The following is a description of a gene set: The change in morphology and behavior of a mature or immature B cell resulting from exposure to a mitogen, cytokine, chemokine, cellular ligand, or an antigen for which it is specific. Human Gene Set: GOBP_B_CELL_ACTIVATION species: Homo sapiens, and this is the list of marker genes: LIG4, IFNA6, MALT1, ITM2A, VAV3, WNT3A, RAG1, INPP5D, STAT5B, ZBTB7A, CDKN1A, LYN, PIK3R1, KMT5C, HMGB3, TGFB1, MIR185, MSH2, NFAM1, DOCK10, TLR4, AQP8, FOXP3, TCF3, NOTCH2, TRAF3IP2, SLC39A10, TNFRSF13B, CD22, IGHE, IFNA7, C3, FCRL1, PRLR, CD19, NSD2, TNFAIP3, IL11, TPD52, CCR6, KMT5B, ITGA4, IFNA21, SPI1, TLR9, POLM, SHLD1, MNDA, CHRNA4, PRKCB, IGHM, BLNK, IL10, IFNA16, LYL1, ITGB1, YY1, IRF2BP2, FOSL2, ABL1, TNFSF4, IFNA17, ADAM10, TYROBP, TBX21, CTLA4, CD81, THEMIS2, EP300, LGALS1, CD40, AHR, CYLD, PTPN2, NHEJ1, FLT3, PHB1, BTK, UNG, ADA (adenosine deaminase), IL9, EPHB2 (EPH receptor B2), IFNW1, NDFIP1, IFNA14, ADAM17, SFRP1, IL6, EXOSC3, SHB, SUPT6H, CASP8, RBPJ, ZAP70, PRKCD, HSPD1, CHRNB2, PARP3, INHBA, DOCK11, PELI1, IL27RA, AKIRIN2, MIR19A, LAX1, CXCR5, SLAMF8, PIK3R2, RIF1, ERCC1, IL5, FCRL5, HMCES, SAMSN1, MLH1, LRRC8A, PLCG2, NBN, IL13, RNF8, MZB1, TNFRSF4, BST2, PAX5, GPS2, TNFSF13B, PTPRJ, PKN1, DCLRE1C, BCL2, FCRL3, MEF2C, VCAM1, LAPTM5, HDAC4, IKZF3, LEF1, ZFP36L2, PLCL2, GPR183, RABL3, FZD9, IGBP1, IFNE, CD40LG, APLF, KLF6, SLC15A4 (solute carrier family 15 member 4), SKAP2, JAK3, STAT6, PIK3CD, BAK1, ATM, IFNA1, INHA, TNFRSF13C, TP53, STAT5A, IFNA2, IL21, HDAC5, BATF, ATAD5, TIRAP, SLC25A5, SP3, LGALS8, CASP3, NFATC2, PAWR, CARD11, MFNG, TNFRSF21, CD38, PAXIP1, CD74, HDAC9, CD86, SYK, C17orf99, XBP1, BCL6, CD79B (NCBI Gene Id 974), TICAM1, EXOSC6, IFNK, BMI1, SLC39A7, TAOK3, PPP2R3C, RASGRP1, IL7, MSH6, HHEX, PCID2, DDRGK1 (NCBI Gene Id 65992), BAX, IFNA8, TOP2B, SHLD3, CD300A, PTPN6, PHB2, BCL3, FCGR2B, SANBR, SH3KBP1 (NCBI Gene Id 94010), RC3H1, IRF8, FLT3LG, CLCF1, DLL1, POU2AF1, PHF14, TP53BP1, MS4A1, BAD, CR2, SPIB, SWAP70, BST1, IL4I1, PTK2B, ICOSLG (inducible T cell costimulator ligand), CD27, FNIP1, IFNA4, CTPS1, BANK1, IL4, KIT, SASH3, RNF168, IFNA5 (interferon alpha 5), ZFP36L1 (NCBI Gene Id 677), TXLNA, MMP14, NTRK1, PRKDC, TFRC, CD28, CD79A, NCKAP1L, SYVN1, IL2, ID2, ZBTB1, NFKBIZ, TNFSF13, NKX2-3, RAG2, CMTM7, NOD2, CD320, LFNG, FOXJ1, ONECUT1, CDH17, IFNA10, EXO1, IRS2, TBC1D10C, DCAF1, ADGRG3, IFNB1 (interferon beta 1), PIK3R3, MIF, MYB, PMS2, DNAJB9, CEBPG, MAD2L2, CD70, AKAP17A, CDKN2A (NCBI Gene Id 1029), CR1, MIR17HG, EZH2, ST3GAL1, GAPT, IL2RG, ITFG2, TNIP2, TCIRG1, PTPRC (protein tyrosine phosphatase receptor type C), IL7R, SHLD2, PCYT1A, AICDA, LAT2, CD180